Given this list of marker genes NT5C, DPYD, SHMT1, UPP1, DPYS, DCTD, TYMS, DUT, TYMP, UPB1, UPP2 (uridine phosphorylase 2), NT5M, here is a description of the gene set: Human Gene Set: GOBP_PYRIMIDINE_DEOXYRIBONUCLEOSIDE_MONOPHOSPHATE_METABOLIC_PROCESS species: Homo sapiens The chemical reactions and pathways involving pyrimidine deoxynucleoside monophosphate, a compound consisting of a pyrimidine base linked to a deoxyribose sugar esterified with phosphate on the sugar.